The following is a description of a gene set: CD40 promotes survival, proliferation, and differentiation of normal B cells but can cause activation-induced cell death in malignant B lymphocytes. CD40 ligand and anti-CD40 antibodies have been used successfully to induce apoptosis in lymphoma lines both in vitro and in xenograft tumor models. Although this makes CD40 an attractive target for antitumor therapies, the response of malignant B cells to CD40 signaling is variable, and CD40 stimulation can enhance proliferation and can increase chemoresistance in some cell lines. It would therefore be useful to identify markers that predict whether a specific cell line or tumor will undergo apoptosis when stimulated with CD40 and to identify targets downstream of CD40 that affect only the apoptotic arm of CD40 signaling. We have analyzed gene expression patterns in CD40-sensitive and CD40-resistant diffuse large B-cell lymphoma (DLBCL) cell lines to identify signaling pathways that are involved in CD40-mediated apoptosis. CD40-resistant lines expressed pre-B-cell markers, including RAG and VPREB, whereas CD40-sensitive cells resembled mature B cells and expressed higher levels of transcripts encoding several members of the CD40 signaling pathway, including LCK and VAV. In addition, CD40-sensitive DLBCL cell lines also displayed constitutive activation of extracellular signal-regulated kinase (ERK) and failed to undergo apoptosis when ERK phosphorylation was inhibited. In contrast, CD40-resistant lines showed no constitutive activation of ERK and no increase in ERK activity in response to CD40 stimulation. Our results suggest that constitutive activation of ERK may be required for death signaling by CD40. studied in species Homo sapiens Human Gene Set: HOLLMANN_APOPTOSIS_VIA_CD40_UP Genes up-regulated in DLBCL (diffuse large B-cell lymphoma) cell lines sensitive to stimulation of CD40 relative to the resistant ones. from publication Hollmann CA, Owens T, Nalbantoglu J, Hudson TJ, Sladek R (PMID 16585179), and this is the list of marker genes: DST, PPP3CC, TUBB2A, TBC1D1, LY9, LSR, TMEM106C, LAP3, KCNN3, RPS4Y1, ALDH4A1, ADAM19, MBD2, NBEAL2, NRGN, ETS2, SDHB, MEST, LEF1, CYB5R1, INTS9, RUNX3, PEMT, HDAC1, PARD6A, PCDHGC3, MFHAS1, CLSTN1, SS18, CPNE3, CD38, TMEM147, HMGB1, MAGEH1 (MAGE family member H1), E2F1, IFI30, SNX10, MAST2, KIAA0930, KDM5D, VAV1 (vav guanine nucleotide exchange factor 1), TSFM, PRPSAP2, CD22, SHMT1, MYO1E, ACAT1, SGCB, IGKC, CDK14, RAC2, MRPL34, CLTB, ISCU, ILRUN, SRP54, ARPP19, HMGB3, SMC4, USP34, COPS3, ASH2L, NUDT11, RGCC, COPS2, NCOR2, RHEBP1, TUBA1B, NR3C1, GTF2F1, ALDH2, PLEKHF2, SBF1, PITX1, TRMT12, PCMT1, HSPH1, FOXN3, CDKN3, IRAG2, GSR, ARF3, BLK, SNRPD1, FANCA (NCBI Gene Id 82952), CUX1, EMC7, MAP4K4, RAP1B, DEPTOR, G3BP1, PTPRC, TCEA1, COPS6, ATP8A1, SERINC5, GCHFR, TIMELESS, MAPK6, CAB39L, SLC25A6, ZNF93, XPO7, MRPS22, PEG10, EAF2, DPYSL2, LSM1, USP13, PRKCA, SLCO4A1, PDLIM2, NUSAP1, ADCK2, AGO1, MYH10, GTF2IRD1, CD86, MEF2C (NCBI Gene Id 4208), PPP2CB, NEMP1, COLGALT1, HBS1L, CREM (cAMP responsive element modulator), RNF126 (ring finger protein 126), PXMP4, STAP1, CD99, LTBP1, AGPAT5, SNU13, PEX3, ARPC2, MYBL1, FLII, RGS13, GNAS, ENSA, MAK16, PTPN22, JCHAIN (NCBI Gene Id 3512), IRF8, CYP39A1, LGALSL, TOX, DUT, CNOT7, PEX1, MCUB, TACC1, BASP1, RFTN1, MRPS33, PPP6R1, CHMP7, EMP3, DDX3Y, PCM1, SNX19, PARP1, COTL1, EPB41L2, FNTA, NQO2, PARN, BTK, RNF19B, LSM4, TUBA1A, SERF2, NSG1 (NCBI Gene Id 27065), CKAP4, GM2A, PDGFD, ENDOD1, DENND1C, LCK, ARPC1B, ITGB1, DDX39A, GTPBP6, SYNE1, TUBA1C, XRCC5, PPP2R2A, DEDD, HGSNAT (heparan-alpha-glucosaminide N-acetyltransferase), MEIS2, ITGB7, PDCD4-AS1, HSPBP1, PAK2, GRK6 (G protein-coupled receptor kinase 6), BIN3, CAP1, MAP4K1, TNFRSF17, RUBCN, ATP6V1B2, SYPL1, PFDN2 (prefoldin subunit 2), SH2B2, NFIB